Given this list of marker genes SLC45A2, GABRB3, NUP155, OCA2, RANBP2, NHLH2, HERC2, SEH1L, TUBGCP6, NDN, POM121, OXT, PRKCZ, NUP62, NUP205, NUP85, UBE2N, NIPA2, NUP107, GABRR3 (gamma-aminobutyric acid type A receptor subunit rho3), NUP58, TPR, GOLGA8S, ATP10A, GOLGA6L2, FEZ2 (NCBI Gene Id 9637), GABRG3, CDKN2C, TYR, MDM2 (NCBI Gene Id 84825), TUBGCP4, NUP160, NUP35, PWRN1, MKRN3, SNORD109A, POMC (proopiomelanocortin), TUBGCP2, PWRN2, NUP98, NUP54 (nucleoporin 54), CDK6, MAGEL2, NPAP1, GABRR2, PCSK1, FSHB, AHCTF1, CYFIP1 (NCBI Gene Id 23191), TP53, GNRH1, FEZ1, PCM1, TUBGCP3, GABRR1, NDC1, MSX1, GABRD, LHB, RB1, CDK4, SNORD108, BBS4, CDKN2A, GHRL, GABRA5, NUP188, GABRG1, NUP133, GHRH, TACR3, SNORD64, SEC13, TUBGCP5, RNF8, SNORD109B, NUP43, NIPA1, INS, DLX5, SNRPN, EIF4E, NUP37, AAAS, NUP214 (NCBI Gene Id 9680), GABRG2, CCND1, GLE1, NUP50, RAE1 (NCBI Gene Id 8480), MDM4, SNURF, BDNF, MIR4508, NGF, KISS1, HTR2C, NUP210, NUP42, CGA, NUP88, CDKN2B, CDC6, NUP153, CCND2, FMR1, E2F1, UBE3A, NUP93, here is a description of the gene set: Human Gene Set: WP_PRADERWILLI_AND_ANGELMAN_SYNDROME Prader-Willi and Angelman syndrome species: Homo sapiens